The following is a description of a gene set: The covalent alteration of one or more fatty acids in a lipid, resulting in a change in the properties of the lipid. species: Homo sapiens Human Gene Set: GOBP_LIPID_MODIFICATION, and this is the list of marker genes: B4GALNT2, TWIST1, GBA1 (glucosylceramidase beta 1), ACADVL, CYP3A5, CROT, PTEN, ACOXL, INPP5J, CRAT, IVD, AUH, AMACR, A3GALT2, PDK4, GCDH (glutaryl-CoA dehydrogenase), MBOAT4, MAPK14, ADIPOR2, ACADM, PHYH, APPL2, ACAA2, ECHDC2, MTMR2, MTMR11, PPARA, ALOXE3, LONP2, HADHB, PLPP2, ACAD11, PRKAG2, BDH2, FMO1 (NCBI Gene Id 2326), ABCD3 (NCBI Gene Id 5825), ACOX2, MBOAT1, DGKZ, LPCAT3, DGKI, MTMR9, DGKA, CYP4A22, PEX7, PLIN5, CHRM5, SAMD1, ACAT1, ABCB11, CYP3A4, ACADL, INPP5K, INPPL1, ABCC9, ABCD2, HAO2, PIP4P1, DECR2, DGAT2, MTMR1, ECHS1, PEX2, ST3GAL4, KLHL25, ADIPOR1, ETFBKMT, DGKG, PEX13, ALOX5, MTM1, PLPP1 (phospholipid phosphatase 1), HSD17B4, GLT6D1, AKT1, MFSD2A, ADH7, POR, CYP1A1, OCRL, CPT1A, ABCD1, DGKE, ST3GAL2, AKT2, FA2H, SGPP1, CPT2, TYSND1, CYP4F3, FABP3, LEP, CYP4V2, SIRT4, DGKB, MTMR6, GBA2, PLA2G7, CYGB, ACACB, GBGT1, PLPP4, IRS2, INPP5A, DGKD, HADHA, ECI1 (NCBI Gene Id 1632), CYP3A7, MTMR10, PLPP5, ABCD4, PLPP6, B3GALT1, AGK, PPARGC1A, B4GALNT1, CPT1B, DGKH, ALDH1L2, SCP2, ADH5, INPP5D, MTMR7, ABO, HAO1, SACM1L, PLPPR4, MBOAT2, PRKAA1, INPP5E, EHHADH, ACOX1, CYP2C8, FMO4, SYNJ2, SLC27A2 (solute carrier family 27 member 2), PLPPR5, PEX5, CYP4F2, SLC35C1, DGKQ, ALOX12, ALOX12B, ALOX15B, HACL1 (NCBI Gene Id 26061), ILVBL, SOX9, IRS1, PIP4P2, DECR1, PLPPR1 (NCBI Gene Id 54886), MTMR3, SGPP2 (NCBI Gene Id 130367), ECI2, MLYCD, CYP2E1, ACAA1, ACADS, MBOAT7, SESN2, APOD, INPP5F, MTLN, MTMR8, RNF213, HADH, INPP5B, MTMR4, FMO2, ACOX3, FIG4, ADIPOQ, PPARD, SLC25A17, MTMR12, ALOX15, ADH4, GDF15, ECHDC1, PLPP3, ETFA, HSD17B10, EPHX2, ACOT8 (NCBI Gene Id 10005), PORCN, MCAT, ACAD10, PLPPR2, ACSM1, SYNJ1, PLPPR3, ETFDH, ECH1, ETFB